Given this list of marker genes DIMT1, COMMD8, CISD1, HYLS1, LRRN3, P2RY14, RECQL, ELAC1, ZEB1-AS1, CD24, SAMTOR (S-adenosylmethionine sensor upstream of mTORC1), ZFP42, UBL5, ZSCAN16, EEF1AKMT1, CACYBP, CD58, LIN9, IMPA1, PRIM1, YEATS4, GRWD1, EXOSC3, VTA1, IFT25 (intraflagellar transport 25), ISOC1, SGO2, KBTBD3, ERI2, ALG6, RPA3, LYSET, CMSS1, GTF2H5, VBP1, SNAPC5, TMEM126A, RPL38, MAGOH, MRPS14, H4C13, ZCCHC10, ZNF616, E2F5, MRPL27, OSTM1, SEC22B, LXN, CLNS1A, DEGS1, DMAC1, WASHC3 (WASH complex subunit 3), MRPL34, EPC2, STYX, ASMT, CCDC90B (coiled-coil domain containing 90B), TM4SF4, NDUFA2, EEF1E1, TSPAN5, SNX14, CCL24, SNRPG, GIN1, ANAPC10, CLLU1, RIDA, ALG8, MRPL50, COPS4, RAD50, GNPNAT1, POT1, CETN3, GTF2H1, RPF2, ZCCHC9, NME7, GLRX, SUCLA2, CEP63, RFC5, TRMT44, CHCHD4, TMEM235 (NCBI Gene Id 283999), TTC1 (tetratricopeptide repeat domain 1), KRCC1, HSPE1, UBE2V2, FAM3C, MDH1, MTFR1, TXNDC9, COPS5, FH, NSG2, MRPS35 (mitochondrial ribosomal protein S35), ATP5IF1, UFSP2, RPS27L, SULF1, ARMC10, MAT2B, NDUFB5, SLC25A12, PPARG, THOC7, TSPAN7, LINC00324, ETFRF1, MESD, HAT1, MKKS, CENPQ, HIGD1A, MRPL51, GIMAP2, METTL5, CCT4, HIKESHI, KRTAP4-1, IPO7, ECHDC1, RPP30, PARPBP, PPP2R3C, C1GALT1C1, TMEM126B, REXO2, FAM220A, ZNF143, NDUFB6, ARFIP1, BPNT1, IKBIP, CCDC126, RPL22, ZNF684, SMIM30, SKP1 (S-phase kinase associated protein 1), UBE2QL1, NDUFB3, KATNBL1, FKBPL, CREBL2, DPY30, RFC4, CCT5, OSTF1 (NCBI Gene Id 26578), EIF3J, ZNF189 (NCBI Gene Id 7743), RPLP1, ZNF585A, KLHL12, EIF4E, TMEM106B, EIF2S1, LCMT2, LINC00526, PDHB, TNFAIP6, NAA30, MPLKIP, CHCHD1, FMC1, NDUFA8, ACADM, GMFG, CFAP70 (NCBI Gene Id 118491), UMPS, HSPA8, ACADS, LIPT2-AS1, DCUN1D1, CHEK2, ADH5, RTN4IP1, PPID (peptidylprolyl isomerase D), MARCHF7 (membrane associated ring-CH-type finger 7), SCOC, TOMM5 (translocase of outer mitochondrial membrane 5), RAD51C, HPF1, SDHD, RFESD, ABHD10, TSNAX, MED20, SURF2, SUMO2, PTRH1, BTF3P12, LMBRD2, PPA2, PSMA5 (proteasome 20S subunit alpha 5), here is a description of the gene set: from publication Querec TD, Akondy RS, Lee EK, Cao W, Nakaya HI, Teuwen D, Pirani A, Gernert K, Deng J, Marzolf B, Kennedy K, Wu H, Bennouna S, Oluoch H, Miller J, Vencio RZ, Mulligan M, Aderem A, Ahmed R, Pulendran B (PMID 19029902) Genes down-regulated in comparison of unstimulated peripheral blood mononuclear cells (PBMC) 1 day after stimulation with YF17D vaccine versus PBMC 21 days after the stimulation. studied in species Homo sapiens The immune responses generated by YF-17D by profiling genes in 25 vaccine recipients were accessed at days 1, 3, 7, and 21 post-vaccination compared to pre-vaccination in PBMCs. The immune responses generated by YF-17D by profiling genes in 25 vaccine recipients were accessed at days 1, 3, 7, and 21 post-vaccination compared to pre-vaccination in PBMCs. Human Gene Set: GSE13485_DAY1_VS_DAY21_YF17D_VACCINE_PBMC_DN